The following is a description of a gene set: species: Homo sapiens Human Gene Set: DESCARTES_FETAL_STOMACH_MESOTHELIAL_CELLS The gene expression program underlying the specification of human cell types is of fundamental interest. The study authors generated human cell atlases of gene expression and chromatin accessibility in fetal tissues. For gene expression, the study authors applied three-level combinatorial indexing to >110 samples representing 15 organs, ultimately profiling ~4 million single cells. The study authors leveraged the literature and other atlases to identify and annotate hundreds of cell types and subtypes, both within and across tissues. Our analyses focused on organ-specific specializations of broadly distributed cell types (such as blood, endothelial, and epithelial), sites of fetal erythropoiesis (which notably included the adrenal gland), and integration with mouse developmental atlases (such as conserved specification of blood cells). These data represent a rich resource for the exploration of in vivo human gene expression in diverse tissues and cell types. from publication Cao J, O'Day DR, Pliner HA, Kingsley PD, Deng M, Daza RM, Zager MA, Aldinger KA, Blecher-Gonen R, Zhang F, Spielmann M, Palis J, Doherty D, Steemers FJ, Glass IA, Trapnell C, Shendure J (PMID 33184181) Marker genes curated from the annotated cluster as represented in the Descartes Human Gene Expression During Development database., and this is the list of marker genes: HHIP-AS1 (HHIP antisense RNA 1), BNC1, HAS1, SPHKAP, TNNT1, RN7SL180P, LINC02360, ALDH1A2, RSPO3, LRP2 (NCBI Gene Id 4036), LINC02232, WT1, GAS1, TFPI2, PDZRN4, COL8A1, BST1, C3, CFB, LINC02643, PTPRQ, TMPRSS11F, NPHS1, SULF1, BDNF, CDON, NXPH2, FAM110C (family with sequence similarity 110 member C), ENSG00000237813, CBLN2, UPK3B, WNT2B, GFPT2, TGM1, AOX1, RSPO1, CAVIN2-AS1